Given this list of marker genes SCYL3, MRPL18, CLN5, TMPRSS11F (transmembrane serine protease 11F), DNER, NSMAF, CPED1, SLC35B1, FAIM, PTK7, TMEM182, CACNA2D1 (NCBI Gene Id 781), MAGI3, DCDC2, S100A14, GPR171, SLC7A9, FGF8, DEFB116, GPR18, YIPF5, ZNF264, NKAIN2, ZC4H2, HRCT1, SOX6, MAGEF1, CLEC6A, TBC1D15, HCCS, HPGDS, MCFD2, AGFG1, SNX7, PAK1, LRRC49, SDCBP, NPTX1, POP4, LAS1L (NCBI Gene Id 81887), SPTA1, HACD2, CCT8, RUNX1T1, COQ10B, TRIM59, RIDA, PBDC1, PRPF38A (pre-mRNA processing factor 38A), GLP1R, FAT1, SRSF11, SHANK3, HMGB4, FOS, SPEN-AS1, MGAT4EP, ETFDH, NKX2-6, BPIFC, LDAH, GCOM1, CASK, ZNF81, CCR4, MED4, IER3IP1, TRAM1, OTULINL, TXNDC12, SPATA17, ORMDL1 (NCBI Gene Id 94101), ALG14, KDELR3, AKR1E2, ANKRD33B, EMB, FOXP2 (forkhead box P2), ATP6V1A, DHX32, RPAP2, EED, CILP, PSPH, VPS13C, KLHL7, CREBRF, FBXL4, EPAS1, LRIT1 (leucine rich repeat, Ig-like and transmembrane domains 1), RARS1, ITGB3BP, FRMD3, PDCL3, WNT8B, RNF148, PHAX, NUP88, PRKAG3, ZNF790, ILDR1, ADAMTS12, DBNDD1, TAF9B, TMPRSS3, LCE1D, VCPKMT, RAB1A, PABPC1, PSTK, ABCD3 (NCBI Gene Id 5825), CFAP36, GRPR, MAGOHB, SMPD4, BNIP3L, MTRR, RBM7 (RNA binding motif protein 7), SCFD1, EXOC3L2 (exocyst complex component 3 like 2), NFIL3, NALF1, ABCA9, IRX3, EHHADH, SLC10A7, ADRB3, ZNF143, LARP4B, TBC1D21, TPP2, PNO1, MTERF3, FAM50A, COMMD3, S1PR5, ZBTB25, POU1F1, MFSD14A, RPL7, RNASE3, MTBP, EIF3E, INSYN2B, DCUN1D1, TMEM167B, KRTAP19-1, INPP1, CMTR2, CYB5R4, SPACA1, PDP1, FMO2, TPD52, IL22RA2, AFG2A, HRG, IPP, BTBD8, CCDC136, ADAT1, MYOD1, SELENOF, TMED3 (NCBI Gene Id 23423), NT5DC1, PDCD10, MMUT, RAB7A, PRG4, UBE2L3, FERMT2, DENR, MR1, ZSCAN5B, CDC42EP4, PTGR2, SELENOP, MMGT1, DLD, TRPC5, ZNF420, NUP50, ATAD1, ACP3, WDR75, MRPL40, PLEKHH2 (pleckstrin homology, MyTH4 and FERM domain containing H2), ADAM8, KLHL41, BMPER, GOT1L1, CD48, ZNF750, WASF1, TNNT3, HDAC2, CBLN4 (NCBI Gene Id 140689), GPC6, NIFK, DISP3, here is a description of the gene set: species: Homo sapiens Human CD14 positive monocytes were purified from healthy volunteers’ blood and cultured in vitro for 4, 12, 24, 72 hours. While culturing, macrophages were activated alternatively with interleukin-4 (IL-4 100 ng/ml) or classically with interferon-gamma (IFNg 100 ng/ml)+tumor necrosis factor (TNF 50 ng/ml) or left without activation. Simultaneously, macrophages were also treated with vehicle (DMSO:ethanol) or 1mM synthetic PPARg agonist, Rosiglitazone. We used Affymetrix microarrays (U133Plus 2.0) to analyze activation and PPARg-induced gene expression changes. Genes down-regulated in macrophages (12h): control versus IL4. from publication Szanto A, Balint BL, Nagy ZS, Barta E, Dezso B, Pap A, Szeles L, Poliska S, Oros M, Evans RM, Barak Y, Schwabe J, Nagy L (PMID 21093321) Human Gene Set: GSE16385_UNTREATED_VS_12H_IL4_TREATED_MACROPHAGE_DN